Given this list of marker genes Lyrm7, Stmp1, Slc25a33, Bcs1l, Uqcc1, Uqcc4, Uqcc2, Uqcc5, Ttc19, Uqcc3, Uqcc6, Uqcrc1, here is a description of the gene set: studied in species Mus musculus The aggregation, arrangement and bonding together of a set of components to form the cytochrome bc(1) complex, a transmembrane lipoprotein complex that it catalyzes the reduction of cytochrome c by accepting reducing equivalents from Coenzyme Q, by the aggregation, arrangement and bonding together of its constituents. Mouse Gene Set: GOBP_RESPIRATORY_CHAIN_COMPLEX_III_ASSEMBLY